Given this list of marker genes TAB2 (NCBI Gene Id 23118), TNF, IKBKG, MAP3K7, RELA, CHUK, IKBKB, NFKB1, IL12A, NFKBIA, IRAK4, IRAK1, TLR5, IL12B, MYD88, IL6, TRAF6, here is a description of the gene set: TLR5-NFKB signaling pathway. Pathway ID: N01566. Pathway type: Reference. Pathway class: nt06517 TLR signaling. Human Gene Set: KEGG_MEDICUS_REFERENCE_TLR5_NFKB_SIGNALING_PATHWAY studied in species Homo sapiens Pathway Definition from KEGG: TLR5 -> (MYD88) -> (IRAK4+IRAK1) -> (TRAF6+TAK1+TAB2) -> IKK -> NFKBIA -> NFKB => (TNF,IL6,IL12A,IL12B)